The following is a description of a gene set: from publication Chen Y, Wang X (PMID 31504780) Human Gene Set: MIR4505 studied in species Homo sapiens Genes predicted to be targets of miRBase v22 microRNA hsa-miR-4505 in miRDB v6.0 with MirTarget v4 prediction scores > 80 (high confidence targets)., and this is the list of marker genes: ORAI2, DNMT3A, DAOA, NCLN, SH3PXD2A, RCAN2, PSG1, GLIS2, LRP1, SEMA3G, CLOCK, PXN, CD28, ERBB2, TMCC2, GGT7, KSR2, GNG13, FBXO41, CIRBP, HMGA1, HSPB6, SEZ6, GPC1, FLNA, CPNE5, ADCY1, PARP16, ST8SIA5, TRARG1, CRHR2, PES1, ADRB3, CLCC1, NCS1, TRABD2B, NFIB, SH3GL1, B3GNTL1, SMPD3, MOB3C, DMBX1, ARHGAP35, SP1, TANC2, SH3KBP1, ENSA, CACNA1E, DES, WDFY1, NECTIN1, UBR5, SCD5, SLCO2B1, PIANP, DHCR24, HCN4, CBFA2T3, LMX1B, RAB11FIP5, C7, SLC7A8, LAYN, SLC30A7, PPP3R1, RNF166, TP53I11, NCAM1, SULF2, CORO1C (NCBI Gene Id 23603), CMTM3, TMEM104, ESPN (NCBI Gene Id 83715), SLC38A1, SARM1, DUSP8, CNOT1, TENM1, RERE, MTCL2, AKAP4, SLC7A1, CBX6, DENND1A, IGFBP5, PLEC, RSPRY1, MNT, TMEM184A, AAK1, EME1, CCL28, FMNL3, ADGRL1, ASIC1, ABCG4, AFF3, PDGFB, SMYD1, GATAD2A, OSBP2, PPP1R16B, GRIK3, NEURL1, CELF3, MARCHF8, ARHGDIA, SNX29, HECTD1, RNLS (renalase, FAD dependent amine oxidase), PACS1, MLKL, PARN, NFIC (NCBI Gene Id 4782), TBC1D13 (NCBI Gene Id 54662), DMWD, ACTMAP (NCBI Gene Id 284325), KIF21B, ZDHHC14, BMP8B, PPP1R7, PPIP5K1, NOVA2, PPFIA2, KLK4, ARNT, HAP1, NAT8L, SLC25A22, CORO1A, ADAP1 (ArfGAP with dual PH domains 1), TSBP1, ZMIZ2, SUV39H1, TPCN1, BBC3, DPYSL5, MAPT, NF2, RIMS4, CCDC28A, NR6A1, ABR (NCBI Gene Id 82701), NACC2, PTAR1, SLAIN2, ZDHHC22, NPLOC4, STAMBP, PAX5, PLXNA4, CASS4, E2F2, PLEKHO1 (NCBI Gene Id 51177), AMACR, RAB43, WDTC1, RASGEF1A, AGAP2, MLPH, BARHL1, FAM53B, GRAMD1B, KCNE4, KCNT1, CHRM1, PLXNA2, SHROOM4, GIPC3, ACVR2B, ASCC2, ECE1, VANGL2, SHB, SELENON, VPS37C, SHISA7, DHX8, GARRE1, CPLX2, SLC43A2, ZFP41, ZBTB2, CLVS1, PHACTR4 (phosphatase and actin regulator 4), MFNG, ATF7, B3GAT1, CEACAM6, PAK4, SDK2, RPGRIP1L, MYO1D, SPEG (striated muscle enriched protein kinase), RAD23A, ST6GALNAC6, GUCA1B, TMEM63C, STK40, CEP85, ZNF395, AMOTL2, UBR2, ARMC6, FAM219A, SLC35E1, JADE2, RING1, EEFSEC, RHOQ, PPP1R3B, HADHA, FOXN3, TEAD2, RAPGEF5, SMIM7, EMILIN3, SYT1, TUBB4B, CIMIP2B, CCDC157, ZNF600, ENG, NNAT, ZNF219, SMAD3, CSK, RALY, SEPTIN3, NFX1, ARID3B, NDST1, SCUBE3, SYNGAP1, WWP1, TNFRSF10C, NFIX, POU2F2, SHISA6 (shisa family member 6), CRTC1, CPTP, MAPKAP1, RXRA, IGF2BP1, KDM6B, ANKS6, TBC1D16, VSX2, P2RX1, FSCN1 (NCBI Gene Id 6624), SMARCD2, SIX3, ANKS1A, PROX1, SDK1